The following is a description of a gene set: Mouse Gene Set: GOBP_JNK_CASCADE studied in species Mus musculus A MAPK cascade containing at least the JNK (MAPK8) MAP kinase. It starts with the activation of JUN3K (a MAPK3K), which activates JNKK a MAP2K), which in turn activates JNK. The cascade can also contain an additional tier: the upstream MAP4K. The kinases in each tier phosphorylate and activate the kinases in the downstream tier. The JNK cascade is activated by stress signals, as well as by G protein-coupled receptors, growth factors, and cytokines, and results in cellular responses such as cell proliferation, cell differentiation, apoptosis and inflammation., and this is the list of marker genes: Gstp3, Dact1, Ptger4, Trpv4, Mapk9, Taok3, Mbip, Dkk1, Birc7, Rapgef1, Mapk14, Wnt7a, Map2k1, Daxx (NCBI Gene Id 13163), Nlk, Atf2, Dusp3, Gstp1, Map4k4, Ccl19-ps5, Prmt1, Map2k4, Cops5, Sirpa, Dab2, Ccl19-ps1, Pycard, Becn1, Zfp622, Mapk8ip2, Rb1cc1, Map3k6, Tirap, Ripk1, Naip1, Mapk13, Gadd45a, Traf6, Grik2, Asb3, Asb15, Map3k12 (NCBI Gene Id 26404), Sfrp5, Il3, Map3k15, Wnt5a, Hacd3, Mapkbp1, Ccl21f, App, Ulk4, Sh3rf2, Mapk11, Klhl31, Myoc, Mdfi (MyoD family inhibitor), Rap2a, Plcb1, Ccl21d, Mapk3, Edar (NCBI Gene Id 547212), Fgd4, Flt4, Mapk8ip1 (NCBI Gene Id 19099), Mapk8ip3, Mapk12, Rasgrp1, Traf4, Ccl21a, Irak4, Ripk2, Phlpp1, Edn1, Lrrk2, Igf1r, Map3k1, Sfrp1, Taok2, Mapk6, Akt1, Mapk7, Pja2, Map4k1, Ccdc88c, Zmynd11, Ccl19 (NCBI Gene Id 24047), Gstp-ps, Prkn, Egfr, Dab2ip, Mdfic2, Stradb, Gstp2, Ror2, Ptk2, Tnfrsf19, Mapk4, Nox1, Map2k3, Traf2, Tlr3, Mapk8, Pdcd4, Hdac3, Cdc42se1, Nrbp1, Fcgr2b, Gps2, Mapk10, Nppa, Dusp22 (NCBI Gene Id 68676), Sh3rf3, F2rl1, Wnt7b, Map3k5, Eda2r, Mfhas1, Map3k13, Aida, Axin1, Sfrp2, Ccl21e, Tnf, Cdc42, Ankrd6, Men1, Irak1, Card9, Hipk2 (NCBI Gene Id 68602), Ercc6, Nod2, Cracr2a, Casr, Per1, Tpd52l1, Ccl19-ps3, Sfrp4, Taok1, Dusp10, Lmnb1, Pbk, Tlr4 (toll-like receptor 4), Ephb1, Pafah1b1, Gadd45b, Sh3rf1, Hipk3, Nrk, Wnt16, Hras, Stk3, Tnfsf11, Tnxb, Naip5, Ltbr, Il1a, Xiap, Slamf1, Serpinf2, Mink1, Naip6, Nphs1, Rassf2, Map2k5, Myd88, Cdc42ep5, Dixdc1, Cbs, Fgf15, Fgf14, Crk, Il1b, Ager, Map2k7, Ccl21b, Itch, Dvl2, Map4k2, Map3k10, Dnaja1, Mturn, Mdfic, Map2k2, Tpbpa, Nfkb1, Ccn2, Map3k20, Marveld3, Gadd45g, Nod1, Tnik, Tgfbr3, Fgf12, Naip2, Hmgb1, Unc5cl, Cyld, Dusp19 (NCBI Gene Id 96977), Mapk15, Mecom, Ncor1, Map2k6, Cd27, Tlr9, Map3k11 (NCBI Gene Id 76541, mitogen-activated protein kinase kinase kinase 11), Rnf13, Ccl19-ps4, Dvl3, Trib1, Ccl19-ps6, Map3k7, Ptpn22, Zfp110, Tlr7, Map1lc3a, Fzd10, Ptk2b, Fktn (fukutin), Smad3, Mapk1